Given this list of marker genes IGLC2, FLNA, PIK3IP1, PRKCH, CD37, IGHA1 (immunoglobulin heavy constant alpha 1), CD160, HLA-DQB1, PRMT1, CDC42, IKZF1 (NCBI Gene Id 55429), RPL31, ZFP36L2, CANX, CES1, ZBTB16, JCHAIN, here is a description of the gene set: from publication Hahtola S, Tuomela S, Elo L, Häkkinen T, Karenko L, Nedoszytko B, Heikkilä H, Saarialho-Kere U, Roszkiewicz J, Aittokallio T, Lahesmaa R, Ranki A (PMID 16914566) Genes down-regulated in monocytes isolated from peripheral blood samples of patients with mucosis fungoides compared to those from normal healthy donors. Human Gene Set: HAHTOLA_MYCOSIS_FUNGOIDES_DN studied in species Homo sapiens PURPOSE: Increased production of Th2 cytokines characterizes Sezary syndrome, the leukemic form of cutaneous T-cell lymphomas (CTCL). To identify the molecular background and to study whether shared by the most common CTCL subtype, mycosis fungoides, we analyzed the gene expression profiles in both subtypes. EXPERIMENTAL DESIGN: Freshly isolated cells from 30 samples, representing skin, blood, and enriched CD4(+) cell populations of mycosis fungoides and Sezary syndrome, were analyzed with Affymetrix (Santa Clara, CA) oligonucleotide microarrays, quantitative PCR, or immunohistochemistry. The gene expression profiles were combined with findings of comparative genomic hybridization of the same samples to identify chromosomal changes affecting the aberrant gene expression. RESULTS: We identified a set of Th1-specific genes to be down-regulated in Sezary syndrome as well as in a proportion of mycosis fungoides samples. In both Sezary syndrome and mycosis fungoides blood samples, the S100P and LIR9 gene expression was up-regulated. In lesional skin, IL7R and CD52 were up-regulated. Integration of comparative genomic hybridization and transcriptomic data identified chromosome arms 1q, 3p, 3q, 4q, 12q, 16p, and 16q as likely targets for new CTCL-associated gene aberrations. CONCLUSIONS: Our findings revealed several new genes involved in CTCL pathogenesis and potential therapeutic targets. Down-regulation of a set of genes involved in Th1 polarization, including the major Th1-polarizing factor, TBX21, was for the first time associated with CTCL. In addition, a plausible explanation for the proliferative response of CTCL cells to locally produced interleukin-7 was revealed.